The following is a description of a gene set: Mouse Gene Set: MIR_1929_5P from publication Chen Y, Wang X (PMID 31504780) studied in species Mus musculus Genes predicted to be targets of miRBase v22 microRNA mmu_miR_1929_5p in miRDB v6.0 with MirTarget v4 prediction scores > 80 (high confidence targets)., and this is the list of marker genes: Tnrc6b, Cdh7, Zbtb42, Inpp4b, Nek9, Fnbp4, Myo1h, C9orf72, Ly6f, Col19a1, Rora, Hgf, Fam234b, Rsf1 (remodeling and spacing factor 1), Jade3, Lpp, Ift70a1, Lrp2bp, Mysm1, Tcf19, Usp46, Snn, Atp6v0a2, Bmp3, Cimap1c, Mmp19 (NCBI Gene Id 58223), Dnmt3l, Fbp1, Epg5, Zfp268, Med13l (mediator complex subunit 13-like), Pls3, Mycbp2, Arl15, Ctnna3, Mgarp, Notch2, Matcap2, Mitf, Tfpi2, Nhsl3, Ubfd1, Shoc2, Galnt3, Ro60, Rexo4, Hnrnpr, Mal, Lpgat1, Cnot11, Dapp1, Rock2, Zfp991, Zfp984, Tmem200a, Spred1, Hfe, Dll1, Imp3, Med13, Kansl1l, Pnrc1, Ptgs1, Tm2d1, Chek1, Uri1, Dpep2, Fbxo11, Bhmt2, Ano4, Uxt, Ccne2, Ppp4r4, Zfp992, Slc8a1, Actr8, C1s1, Dab1, Lrtm1 (leucine-rich repeats and transmembrane domains 1), Qrfprl, Pdcd6ip